The following is a description of a gene set: Human Gene Set: GOBP_AXONEMAL_CENTRAL_APPARATUS_ASSEMBLY The aggregation, arrangement and bonding together of a set of components to form an axonemal central apparatus. species: Homo sapiens, and this is the list of marker genes: DNAJB13, RSPH9, CFAP91, SPAG17, HYDIN, SPEF1